Given this list of marker genes NCK1, DNAJC3, EIF2AK3, EIF2S1, DDX3X, EIF4G1, PPP1R15A (NCBI Gene Id 23645), SESN2, MAP3K20, NCK2, here is a description of the gene set: Modulation of the frequency, rate or extent of translation as a result of endoplasmic reticulum stress. species: Homo sapiens Human Gene Set: GOBP_REGULATION_OF_TRANSLATION_IN_RESPONSE_TO_ENDOPLASMIC_RETICULUM_STRESS